Given this list of marker genes Tut4, Or4c15b, Med24, Nedd4, Uggt2, Ctr9, Izumo3, Herc1, Ppp1r42, Alpl (alkaline phosphatase, liver/bone/kidney), Mup5, Gm23437, Sh3bp2, Dennd5b (DENN domain containing 5B), Gm11760, Gm13675, Ahcyl2, Or2l13b, Pign, Spdya, Or8k30, Or10d1b, Or6c217, Gm23032, Prkaa2, Gm14933, Inpp4b, Ggcx, Gm10709 (NCBI Gene Id 100039782), Npy6r, Vmn2r-ps123, Gm12102, Or5w11, Or8k22, Atp11b, Gm11779, Vax1, Arhgap12, Med23, Or5al6, Gm8869, Psg26, Vmn2r-ps68, Ppfia3, Gm9332, Gm10222, Fntb, Gm13798, Or8h8, Cyp2c50, Gm14214, Zfp146, Gm9060, Snx2, Car3, Lekr1, Adgrv1, Tnrc6a, Gm11839, 4930441J16Rik, Gm8978, Gm24176, Aff4, Ctss, 4930562D21Rik, Pcdh7 (protocadherin 7), Gm24069, 4932441J04Rik, Gm29601, Or4n4b, Mir344f, Cdk14, Or10ag2, Gm25148, here is a description of the gene set: from publication Yevshin I, Sharipov R, Kolmykov S, Kondrakhin Y, Kolpakov F (PMID 30445619) species: Mus musculus Mouse Gene Set: PHF13_TARGET_GENES Genes containing one or more binding sites for (Phf13) in their promoter regions (TSS -1000,+100 bp) as identified by GTRD version 20.06 ChIP-seq harmonization.